The following is a description of a gene set: species: Homo sapiens Mutation-activated RET to PI3K signaling pathway. Pathway ID: N01065. Pathway type: Variant. Pathway class: nt06214 PI3K signaling. Human Gene Set: KEGG_MEDICUS_VARIANT_MUTATION_ACTIVATED_RET_TO_PI3K_SIGNALING_PATHWAY Pathway Definition from KEGG: RET* -> PI3K -> PIP3 -> AKT -> MTOR, and this is the list of marker genes: PIK3CD, AKT2, RET, AKT1, AKT3, MTOR, PIK3CA, PIK3CB